Given this list of marker genes ATP6V0D1, ATP6V1B2, ATP6V1G3, ATP6V1A, ATP6V1C1, ATP6AP2, ATP6V1F, ATP6V1G2, ATP6AP1, ATP6V0C, ATP6V1D, CLCN3, ATP6V1E1, SLC17A7, ATP6V1B1, ATP6V0A4 (NCBI Gene Id 536), ATP6V1G1, ATP6V0A1 (NCBI Gene Id 535), here is a description of the gene set: The acidification of the synaptic vesicle lumen via transport of protons into the vesicle. The resulting electrochemical gradient powers neurotransmitter loading. studied in species Homo sapiens Human Gene Set: GOBP_SYNAPTIC_VESICLE_LUMEN_ACIDIFICATION